Given this list of marker genes Reg3g, Crnn, Tgm1, Stxbp4, Trp63, Twist2, Reg3a, Kif3a, Extl3, Fgf10, Fgf7, Has2 (hyaluronan synthase 2), Notch2, Cdh3, Lrg1, Mdk, here is a description of the gene set: Mouse Gene Set: GOBP_POSITIVE_REGULATION_OF_KERATINOCYTE_PROLIFERATION species: Mus musculus Any process that increases the rate, frequency or extent of keratinocyte proliferation. Keratinocyte proliferation is the multiplication or reproduction of keratinocytes, resulting in the expansion of a cell population.